Given this list of marker genes MDH1, ADIPOR2, BHMT (betaine--homocysteine S-methyltransferase), AKAP11, ELANE, NETO2, AASS, IGF1 (NCBI Gene Id 3479), SERPINF1, MAPKAPK2, ELOVL5, CYP2E1 (cytochrome P450 family 2 subfamily E member 1), PNLIPRP1, REPS1, MCM10, ALDH1A1, DBI, GOT1, ZG16 (NCBI Gene Id 653808), ACSL1, HPD, MTARC1, OTC, FABP1, PCK1, ZC2HC1C, HSD17B10, IL1RAP, TDO2, RARRES1, BAAT, EGFR, AQP8, PPCS, KYNU, GPR37, GSTO1, GHR, C4BPA, RGN, CFH, REG1A, HAO1, KLK5, HSD11B1, ME1, ORM2 (NCBI Gene Id 5005), PNLIP, AKR1C1, PXMP2, CYP2F1, ORM1, LECT2, TMEM222, CTRC, CCDC90B, NR1H3, ITPR1, ABCG2, DCT, EFNA4, HAL, CFHR1, OAT, here is a description of the gene set: Genes down-regulated in hepatocellular carcinoma (HCC) induced by overexpression of E2F1. species: Homo sapiens Genetically modified mice have been extensively used for analyzing the molecular events that occur during tumor development. In many, if not all, cases, however, it is uncertain to what extent the mouse models reproduce features observed in the corresponding human conditions. This is due largely to lack of precise methods for direct and comprehensive comparison at the molecular level of the mouse and human tumors. Here we use global gene expression patterns of 68 hepatocellular carcinomas (HCCs) from seven different mouse models and 91 human HCCs from predefined subclasses to obtain direct comparison of the molecular features of mouse and human HCCs. Gene expression patterns in HCCs from Myc, E2f1 and Myc E2f1 transgenic mice were most similar to those of the better survival group of human HCCs, whereas the expression patterns in HCCs from Myc Tgfa transgenic mice and in diethylnitrosamine-induced mouse HCCs were most similar to those of the poorer survival group of human HCCs. Gene expression patterns in HCCs from Acox1(-/-) mice and in ciprofibrate-induced HCCs were least similar to those observed in human HCCs. We conclude that our approach can effectively identify appropriate mouse models to study human cancers. from publication Lee JS, Chu IS, Mikaelyan A, Calvisi DF, Heo J, Reddy JK, Thorgeirsson SS (PMID 15565109) Human Gene Set: LEE_LIVER_CANCER_E2F1_DN